Given this list of marker genes St3gal3, Acan, Chst2, St3gal2, Slc35d2, Lum, Kera, Chst5, Omd, B3gnt3, B4galt6, St3gal4, here is a description of the gene set: part of: Keratan sulfate/keratin metabolism electronically inferred by orthology from the curated human pathway This event has been computationally inferred from an event that has been demonstrated in another species.<p>The inference is based on the homology mapping from PANTHER. Briefly, reactions for which all involved PhysicalEntities (in input, output and catalyst) have a mapped orthologue/paralogue (for complexes at least 75% of components must have a mapping) are inferred to the other species. studied in species Mus musculus Reactome Pathway: Keratan sulfate biosynthesis